The following is a description of a gene set: Human Gene Set: HP_HYPOPLASTIC_IRIS_STROMA Underdevelopment of the stroma of iris. studied in species Homo sapiens Hypoplastic iris stroma, and this is the list of marker genes: MAFB, MITF, PAX3, PAX6, PITX2, FOXC1, SALL4, CHN1